Given this list of marker genes Eef2, Nop53, Gtf3a, Tst (NCBI Gene Id 22117), Mrpl18, Rpl3, Rpl7, Rrs1, Rpl11, Mdm2, Rpl4, Rpf2, Rpl5 (ribosomal protein L5), Hmgb1, here is a description of the gene set: Mouse Gene Set: GOMF_5S_RRNA_BINDING Binding to a 5S ribosomal RNA, the smallest RNA constituent of a ribosome. species: Mus musculus